The following is a description of a gene set: Mouse Gene Set: GOMF_INTERMEDIATE_FILAMENT_BINDING Binding to an intermediate filament, a distinct elongated structure, characteristically 10 nm in diameter, that occurs in the cytoplasm of higher eukaryotic cells. Intermediate filaments form a fibrous system, composed of chemically heterogeneous subunits and involved in mechanically integrating the various components of the cytoplasmic space. species: Mus musculus, and this is the list of marker genes: Flg, Fam83h, Ubqln1, Eppk1, Nme2, Nme1, Krt74, Mtm1, Sirt1, Synm, Vim, Pkp2 (plakophilin 2), Krt14, Nes